The following is a description of a gene set: Any process that stops, prevents, or reduces the frequency, rate or extent of megakaryocyte differentiation. studied in species Mus musculus Mouse Gene Set: GOBP_NEGATIVE_REGULATION_OF_MEGAKARYOCYTE_DIFFERENTIATION, and this is the list of marker genes: Prmt1, Myb, Cib1, Gabpa, Pf4